Given this list of marker genes TSNAX, TERT, PRKRA, TSN, HENMT1, DICER1, TARBP2, AGO2, here is a description of the gene set: studied in species Homo sapiens A process leading to the generation of a functional small interfering RNA (siRNA). Includes the cleavage of double-stranded RNA to form small interfering RNA molecules (siRNAs) of 21-23 nucleotides. May also include amplification of the siRNA by RNA-directed RNA polymerase. Human Gene Set: GOBP_SIRNA_PROCESSING